Given this list of marker genes TGFBR2, LBR, SLC25A24, CHUK, DOCK6, NOG, KCNN3, here is a description of the gene set: Aplasia (absence) of the distal phalanges. studied in species Homo sapiens Absent distal phalanges Human Gene Set: HP_ABSENT_DISTAL_PHALANGES